The following is a description of a gene set: Tracheal stenosis Human Gene Set: HP_TRACHEAL_STENOSIS studied in species Homo sapiens, and this is the list of marker genes: FRAS1, LTBP3, BUB1, EXTL3, PCNT, SLC26A4, EBP, GRIP1, RSPO2, SLC26A2, KCNJ10, RMRP, HOXD13, DHCR7, DDRGK1, HYLS1, SOX9, ZEB2, ADAMTSL2, TBX4, ARSL, KIF7, MAP3K7, WNT3, SMAD4, IDUA, FOXI1, FLNB, FREM2, MGP